The following is a description of a gene set: Binding to a clathrin light chain. Mouse Gene Set: GOMF_CLATHRIN_LIGHT_CHAIN_BINDING studied in species Mus musculus, and this is the list of marker genes: Hip1, Nsg2, Caly, Cltc, Hip1r, Nsg1